The following is a description of a gene set: Genes encoding cell cycle related targets of E2F transcription factors. from publication Liberzon A, Birger C, Thorvaldsdóttir H, Ghandi M, Mesirov JP, Tamayo P (PMID 26771021) Human Gene Set: HALLMARK_E2F_TARGETS studied in species Homo sapiens, and this is the list of marker genes: CCP110, NBN (NCBI Gene Id 4683), CHEK2, UBE2T, DEPDC1, ATAD2, SUV39H1, GINS3, CDC25A, DCTPP1, LBR, TUBG1 (tubulin gamma 1), SMC6, HMMR, GINS4 (NCBI Gene Id 84296), ORC6, STAG1, HMGB2, PRDX4, LMNB1, SHMT1, SPC24, RAD21, NUP153, ANP32E, XPO1, DDX39A, PRKDC, POLE4, SPC25, SLBP, TACC3, PCNA, GSPT1, POLE, TP53, CENPM, TBRG4, MYC, KIF22, HUS1, TCF19 (NCBI Gene Id 95292), HMGB3 (NCBI Gene Id 3149), HNRNPD, ORC2, DCK, BUB1B, MCM3, MLH1, CDK1, KPNA2, MCM4 (NCBI Gene Id 780917), NUP107, DLGAP5, EED, NUDT21, DUT, TRIP13, ASF1A, PSMC3IP, SRSF2, TIMELESS, SMC1A, ASF1B, BARD1, LYAR, MELK, LUC7L3, RPA3 (replication protein A3), PRPS1, NAA38, CDKN1B, RAN, EXOSC8, CCNE1, NOP56, RRM2, AURKB, ILF3, MCM6, MCM5, NAP1L1 (nucleosome assembly protein 1 like 1), RAD50, EZH2, PMS2, CKS2, POP7, TOP2A, UNG, NASP, WDR90, PLK1 (NCBI Gene Id 5347), TMPO, MRE11 (NCBI Gene Id 4361), RBBP7, DONSON, SNRPB, CDK4, TIPIN, NUP205, H2AX, SPAG5, CDKN2C, DIAPH3, CDKN1A, MAD2L1, USP1, TFRC, PTTG1, SMC3, E2F8, PSIP1, BIRC5, CDKN3, ING3, H2AZ1, CDC25B, CTPS1, PA2G4, CCNB2, RPA1, MYBL2, TUBB, TK1, UBR7, NOLC1, RANBP1, CBX5, MXD3, PLK4, GINS1, ESPL1, PPP1R8, CDC20, AK2 (adenylate kinase 2), PAICS, DSCC1, PPM1D, DNMT1, MSH2 (NCBI Gene Id 8169), PRIM2, CKS1B (NCBI Gene Id 88475), BRMS1L, RPA2, KIF4A, JPT1 (Jupiter microtubule associated homolog 1), BRCA1, IPO7, KIF18B, PHF5A (NCBI Gene Id 84844, PHD finger protein 5A), POLD1, NME1, CHEK1, CENPE, CIT, RFC1, POLD3, MCM2, MCM7, HMGA1, WEE1, TRA2B, CNOT9, CSE1L, PDS5B, DCLRE1B, CDCA3, SMC4, HELLS, KIF2C, ZW10, LIG1, RFC2, POLA2 (DNA polymerase alpha 2, accessory subunit), RAD1, DEK, RFC3, MMS22L, CDCA8, EIF2S1, RNASEH2A, RAD51C (RAD51 paralog C), POLD2, NCAPD2, BRCA2, AURKA, SRSF1, STMN1, CTCF, SYNCRIP, CDKN2A, RACGAP1, MKI67, UBE2S, PAN2, XRCC6, PNN, MTHFD2, RAD51AP1, SSRP1